The following is a description of a gene set: Glycogen, a highly branched glucose polymer, is formed and broken down in most human tissues, but is most abundant in liver and muscle, where it serves as a major stored fuel. Glycogen metabolism has been studied in most detail in liver and skeletal muscle. Glycogen metabolism in other tissues has not been studied as extensively, and is thought to resemble the muscle process.<br>Glycogen synthesis involves five reactions. The first two, conversion of glucose 6-phosphate to glucose 1-phosphate and synthesis of UDP-glucose from glucose 1-phosphate and UTP, are shared with several other pathways. The next three reactions, the auto-catalyzed synthesis of a glucose oligomer on glycogenin, the linear extension of the glucose oligomer catalyzed by glycogen synthase, and the formation of branches catalyzed by glycogen branching enzyme, are unique to glycogen synthesis. Repetition of the last two reactions generates large, extensively branched glycogen polymers. The catalysis of glycogenin glucosylation and oligoglucose chain extension by distinct isozymes in liver and nonhepatic tissues allows them to be regulated independently.<br>Cytosolic glycogen breakdown occurs via the same chemical steps in all tissues but is separately regulated via tissue specific isozymes and signaling pathways that enable distinct physiological fates for glycogen in liver and other tissues. Glycogen phosphorylase, which can be activated by phosphorylase kinase, catalyzes the removal of glucose residues as glucose 1-phosphate from the ends of glycogen branches. The final four residues of each branch are removed in two steps catalyzed by debranching enzyme, and further glycogen phosphorylase activity completes the process of glycogen breakdown. The first glucose residue in each branch is released as free glucose; all other residues are released as glucose 1-phosphate. The latter molecule can be converted to glucose 6-phosphate in a step shared with other pathways (Villar-Palasi & Larner 1970; Hers 1976).<br>Glycogen can also be taken up into lysosomes, where it is normally broken done by the action of a single enzyme, lysosomal alpha-glucosidase (GAA). studied in species Homo sapiens part of: Metabolism of carbohydrates and carbohydrate derivatives Reactome Pathway: Glycogen metabolism, and this is the list of marker genes: RPS27A, UGP2, PHKB, NHLRC1, PHKA1, UBA52, CALM1 (NCBI Gene Id 801), PYGB, GYS2, PHKG1, GYG2, EPM2A, GYS1, PYGM, GYG1, GBE1, AKR1E2, GAA, UBB, PYGL, PHKA2, UBC, PPP1R3C, PGM1, PHKG2, AGL